The following is a description of a gene set: from publication Chen Y, Wang X (PMID 31504780) Human Gene Set: MIR323A_5P Genes predicted to be targets of miRBase v22 microRNA hsa-miR-323a-5p in miRDB v6.0 with MirTarget v4 prediction scores > 80 (high confidence targets). species: Homo sapiens, and this is the list of marker genes: ZBTB9, NAPEPLD, G0S2, STIM1, CLDN3, GIMAP4, PRR9, PDE6H, PAQR3, MYLK2, SLC5A1, DDB1, SYNPO2L, DCUN1D4, PKD2, BCAM, RBBP4, LSM3, KLF2, SEZ6, KCNMA1, TOMM6, HNRNPA2B1, NKD2, SP3, AMD1, CAPN6, NFIA, SPOP, BMERB1, KLF6, MIER3, GK, XKR6, ATAT1, PPP1R12A (protein phosphatase 1 regulatory subunit 12A), CNTF, SIRPA (signal regulatory protein alpha), SEPTIN7, IQCH, CRB1, COL5A2, SLC66A3, DDX39B, SAXO1